The following is a description of a gene set: An activity, driven by ATP hydrolysis, that modulates the contacts between histones and DNA, resulting in a change in chromosome architecture within the nucleosomal array, leading to chromatin remodeling. studied in species Homo sapiens Human Gene Set: GOMF_ATP_DEPENDENT_CHROMATIN_REMODELER_ACTIVITY, and this is the list of marker genes: CHD2, CHD5, SMARCA1, INO80, SMARCAD1, CHD8, ERCC6, CHD6, MYD88, CHD1, SMARCA2, CHD3, CECR2, CHD4, SMARCA4, RSF1, CHD1L, SMARCA5, RAD54L2, CHD7